Given this list of marker genes Axin1 (NCBI Gene Id 12005), Epb41l5, Epha2, Nodal, Tcf7l1, here is a description of the gene set: The process in which the anatomical structures of the axial mesoderm are generated and organized. species: Mus musculus Mouse Gene Set: GOBP_AXIAL_MESODERM_MORPHOGENESIS